The following is a description of a gene set: electronically inferred by orthology from the curated human pathway This event has been computationally inferred from an event that has been demonstrated in another species.<p>The inference is based on the homology mapping from PANTHER. Briefly, reactions for which all involved PhysicalEntities (in input, output and catalyst) have a mapped orthologue/paralogue (for complexes at least 75% of components must have a mapping) are inferred to the other species. species: Mus musculus Reactome Pathway: O-linked glycosylation part of: Post-translational protein modification, and this is the list of marker genes: Galnt15, Gcnt3, Chst4, Fut10, Adamts4, Muc20, Cfp, St6galnac3, Slc35a4, Adamtsl5, Fktn, C1galt1, Adamts18, Muc15, St3gal2, Gcnt7, Mgat5b, Pomt1, St6galnac2, Pofut2, B3gnt8, Adamtsl4, Adamts1, Muc1, Adamts12, Sema5b, Thbs2, Adamts13, Adamtsl2, B3gnt3, B3galnt2, Muc5b, A4gnt, Galnt12, B3gnt9, Pomk, St3gal4, Dag1, Muc17, Galnt1, B4galt6, Thsd4, St6galnac4, Adamts15, Adamtsl1, Muc13, Pomt2, Galntl5, Emid1, Fkrp, Mmrn1, Sbspon, Fut11, B3gntl1, Galnt4, Galnt14, B3gnt6, St3gal3, Galnt9, Spon1, Crppa